Given this list of marker genes TREM2 (triggering receptor expressed on myeloid cells 2), CX3CL1, GBA1, CSF1, CSF1R, IL34, NDP (NCBI Gene Id 4693), CLU, IL33, here is a description of the gene set: The expansion of a microglial cell population by cell division. studied in species Homo sapiens Human Gene Set: GOBP_MICROGLIAL_CELL_PROLIFERATION